The following is a description of a gene set: Genes predicted to be targets of miRBase v22 microRNA mmu_miR_878_5p in miRDB v6.0 with MirTarget v4 prediction scores > 80 (high confidence targets). studied in species Mus musculus Mouse Gene Set: MIR_878_5P from publication Chen Y, Wang X (PMID 31504780), and this is the list of marker genes: Nxnl1, Rad23b, Phc3, Spin1, Ptp4a1, Arrdc3, Lmx1a, Snrnp27, Nid1, Elk4, Spink5, Igfbp3, Dpy19l3, Gfod1, Prrg1, Etnk1, Flrt3, Baz1a, Rnf24, Map3k20, Mastl, Acly, Senp8, Rcbtb2, Abcd3 (NCBI Gene Id 99893), Acad11, Mid2, Cpne8, Clec7a, Cstpp1, Golph3, Pax6, Itih5